Given this list of marker genes KMT2A, MBD5, TAF4, ACTG1, THUMPD1, SHH, EP300, CTCF, KMT2D, MAB21L1, CHST14, KCTD1, FILIP1, LMBR1, KCNH1, NALCN, AHDC1, ERF, B3GLCT, SCNM1, CNTNAP2, DNMT3A, MAN2C1, ASXL3, CREBBP, ACTB, NAA10, ALX3, TWIST1, ARSL, CENPF, KDM6A, here is a description of the gene set: species: Homo sapiens Reduced distance from the anterior border of the naris to the subnasale. Short columella Human Gene Set: HP_SHORT_COLUMELLA